Given this list of marker genes FANCD2, EGFR, HSP90B1, ERCC1, UHRF2, FAN1, PTEN, REV1, NBN, XRCC2, UBE2T, CEBPD, FANCI, FANCF, FANCL, FANCM, DCLRE1B, BRCA1, MAD2L2, FAAP100, ERCC4, MCM2, CTDP1, FAAP20, MRE11, CENPX, ATR, USP1, SLX4, MEN1, FAAP24, SMARCA4, CENPS, FANCA, RAD51, RAD51C, UHRF1 (ubiquitin like with PHD and ring finger domains 1), ATM, BRIP1, PALB2, RFWD3, RAD50, FANCB, BRCA2, FANCE, FANCG, FANCC, here is a description of the gene set: Fanconi anemia studied in species Homo sapiens Human Gene Set: WP_FANCONI_ANEMIA